The following is a description of a gene set: Mouse Gene Set: REACTOME_TRANSCRIPTIONAL_ACTIVATION_OF_MITOCHONDRIAL_BIOGENESIS Transcriptional activation of mitochondrial biogenesis species: Mus musculus, and this is the list of marker genes: Cycs, Acss2, Gabpa, Sod2, Idh2, Sirt5, Gabpb1, Glud1 (glutamate dehydrogenase 1), Gm10053, Sirt4, Sirt3